Given this list of marker genes CNTFR, PHLDB2, MIGA2, BICRAL, COL4A2, PI4K2A, ICMT, UBE2R2, TRA2B, DR1, RALGDS (NCBI Gene Id 95849), ELOVL4, TAFA4, TBC1D22A, TMEM109, H4C1, KCTD12, STAM, UBE4B, ACOT7, C4orf46, ARHGAP24, SORT1, ZNF395, NRF1, ARK2N, AP1S2, KCNJ2, PCNP (PEST proteolytic signal containing nuclear protein), FSTL1, PPARA, EMB, IPO4, SYAP1, ATP11A, MAP1B, OPCML, DIO2, CXCR4, ADAM11, SACS, IKZF4 (IKAROS family zinc finger 4), BRD8, ELF1, TLNRD1, OSBPL3, SLC25A24, TGFBI, MDGA1, KLF5, KLHL18, SLC10A3, AEBP2, CEP104, ZNF131 (zinc finger protein 131), VAV3, CNNM1, PPP2R5D, KCNK4, QKI, RAP2C, LARP1, DBNL, PDK4, SLC39A14, JPT2 (NCBI Gene Id 90861), ID4, GABBR2, COL9A1, SMURF2, TGOLN2, NAP1L1, PRDM1, CD47, TBC1D8, AP2M1, BCL11A, PTBP3, NR5A2 (nuclear receptor subfamily 5 group A member 2), HOXA11, CAMKK2, PCDH7, UHRF1, ULK2, PRRT2, FBXL2, DGKB, HECW2, ITM2C, ARHGAP39, TRAF7, TLK1, AXL, CBX1, FBXL3, C2CD2, SYT10, ANO1, NID2, PLPP6, FAM107B, ATG14, IGF2BP2 (NCBI Gene Id 10644), CCSER2, PLBD2, NEDD4, TMCC1, HMGA2, BCL6 (NCBI Gene Id 604), ADGRL1, SH3BGRL2, ARHGEF5, PDGFRB, DYRK1A, CAPZA1, PRRX1, FGF12, ITPKC, TAB2, FYTTD1, SORBS3, MBNL1, STC1, AFAP1, ZNF263, EGR3, SLC9A1, XRN1, PIK3R3, ZNF354A (NCBI Gene Id 6940), CBX6, GMEB2, BCLAF1 (BCL2 associated transcription factor 1), UBAP2, LZTS3, YIPF4, TAFA5, ACVR1B, DIAPH1, FLRT3, COL12A1, MTHFD2, PGAP1, FNBP1, SLC30A8, DTNA (dystrobrevin alpha), HIC2, USP6, MYH1, SLC35B3, ARL4C, IKZF5, SLC6A6, C1QL1, PCGF6, TOGARAM1, EHD4, LHFPL6, PGRMC2, GOLPH3, CNTN4, CNNM4, HUNK (NCBI Gene Id 30811), SMARCD2, ALCAM, FAF2, SIN3A (NCBI Gene Id 25942), TRIM2, VAMP1, SPTLC2, TMEM260, MAEA, FURIN, IGF2BP3, CEP350, RIC8B, UBE2Q1, COL15A1, FBXL19, PPP6R3, ATP1B1, ZNF655, PHF20L1, CRIM1, SLC12A5, GALNT3, ESYT2 (NCBI Gene Id 57488), PHF8, FARP1, UBE3C, SIRT1, YBX3, FOXP1, RBFOX2, RET (ret proto-oncogene), RNF19A, ARPP21, SH2B3, PTBP1, TNRC6B, EDEM3, CELF6, UBASH3B, EPHB2, GPAM, ST8SIA4, HARS2, DSTYK, PDE7B, DRD2, ASIC1, HIPK1, PHOSPHO1, NEK1, FAM13C, TENM1, PTBP2, UBE2Z, CPEB2, STK3 (serine/threonine kinase 3), ERC2, KCNMA1, MAGT1, DLX3, HDAC5, HOXC13, ARHGDIA, SOCS5, CDC73, TULP4, FNDC3B (NCBI Gene Id 64778), FRY, P4HA2, PARG, SLC20A2, LUC7L2, SNX7, EVI5L, SCRIB, AMBRA1 (NCBI Gene Id 55626), PACSIN1, OTUD4, ARHGEF17, ADAMTS6, SYNJ1, GOPC, DHX40, TENT5C, LURAP1L, NFKB1, CMTR2, DEDD, LRRTM4 (NCBI Gene Id 80059), FLI1, JAKMIP2, ADAMTS13, M6PR, PPP1R13B, AGFG1, PRUNE1, ARPC1A, PWWP3B, ARMCX2, DYNC1LI2, SRGAP3, TESK2, PLSCR3, MRFAP1, STARD13, TRIM55, KIF21A, SNX16 (sorting nexin 16), CC2D1B, MAF, ZNF654, TSC22D3, RIMS3, SLC33A1, SLC50A1, KITLG, CA7, FBRS, NCOR2, SEMA6D, RAB8A, MAP1A, GSKIP, VAMP3, MYPN, PURA, DOCK9, SLC30A3, JUP, CCDC6, ANKRD12, LIN28A, FRMD6, FOXN2, ZNF365, CTHRC1, NSD2, CALB2, ONECUT1, KLHL3, INSIG1, CSNK1G2 (casein kinase 1 gamma 2), STX1A, KIF1C, ASXL1, SHC1, DIXDC1 (DIX domain containing 1), NOTCH2, KLHL1, NALF2, ENTPD5, MMP16, SCN2B, LZTS2, SNIP1, SPECC1L, FAM117B, BRPF3, HNF1B (HNF1 homeobox B), RBM24, RNF128, PAK4, EPHA7, SPART, KLF12, GRSF1, FBXW2, MAP7 (microtubule associated protein 7), LIN28B, ARID3B, SIX4, SEZ6, RNF144A, DENND1A, GPR85, ATP8B2, FBN2, SLC27A4, MYH9, RIMS2, BRD4, GAD1, NTNG1, SFXN2, REEP4, SHTN1, PMP22, KIAA1217, CREB5, MDGA2 (MAM domain containing glycosylphosphatidylinositol anchor 2), NFASC, YPEL2, RBMS3 (NCBI Gene Id 27303), DIPK2A, CREBRF, ZKSCAN1, SON, RTN4RL1, SGCD, DYRK1B, HMG20A, SPTSSA, OTUD7B, NPTX1, PANK2 (pantothenate kinase 2), PCSK2, ARFIP2, ZNF324, RHOBTB1, BAHD1, DNAJB1, LIN7C, CELF4, SRSF6, OSBPL11, PHTF2, TLN1, POU3F2 (NCBI Gene Id 5454), DNAJA4, RASD2, PIGZ, ELAVL1, DDX17, RIMS4, ITM2B, PCSK6, SLC31A2, CCAR2, CSGALNACT1, DOLPP1, NXPE3, CARM1, AP4E1, RBM5, TXNDC5 (thioredoxin domain containing 5), LMNA (lamin A/C), FOXP4, SIX5, TSC22D2, CCNE2, ACACA, RNF24, TBPL1, ZDHHC5, FBN1, PAK2, PANK3, DSE, BACE1, RNF111, CNTN3, ANK2, KLHL42 (NCBI Gene Id 57542), NMT1, LAMP1 (lysosomal associated membrane protein 1), SENP1, SCYL3, FNIP1, WNT4, FOXG1 (NCBI Gene Id 2293), TRPM7, AUH, ZNF362, CMTM6, ARID1A, SNRK, HLCS, EIF5, MTPN, MARCHF6, VGLL4, ZBTB41, SNX25, AMMECR1L, MAP2K7, RNF150, ARHGEF2, PDGFC, GCH1, CLOCK, RANBP17, MAN1A2, GZF1, LRCH4, NDRG1, SRSF10, AMMECR1, CCDC43, ACTR1A, SYT9, KALRN, ARID1B, TNFRSF21, PALMD, CNNM2, GOT1, MAPKAPK2, GNPNAT1, GRHL1, RANBP2, RPS6KA4, LRRC1, STK38L, ZNF319, MRRF, DNAJC14, CUL4A, CSNK1A1, AP3B1 (adaptor related protein complex 3 subunit beta 1), CHST15, LPP, MYRF (NCBI Gene Id 84755), ZNF280D, LDLRAP1, GAB2 (GRB2 associated binding protein 2), WDTC1, PCGF5, EIF4E, MAP3K3, BCAP29, BTBD10, CCNG1, NCOA1, RUNX2, ESYT1, KCNMB2, MYO1C, ADAMTS5, SLC19A2, DCUN1D4, CPEB4, RAB34 (RAB34, member RAS oncogene family), PYGO2, PRDM10, FNBP1L, ERBIN, SHROOM2, here is a description of the gene set: Genes having at least one occurence of the motif ACCAAAG in their 3' untranslated region. The motif represents putative target (that is, seed match) of human mature miRNA hsa-miR-9 (v7.1 miRBase). species: Homo sapiens Human Gene Set: ACCAAAG_MIR9